The following is a description of a gene set: studied in species Homo sapiens Regulation by c-FLIP Human Gene Set: REACTOME_REGULATION_BY_C_FLIP, and this is the list of marker genes: FASLG, FAS, TRADD, TNFRSF10A, CFLAR, FADD, TRAF2, TNFRSF10B, CASP8, RIPK1, TNFSF10